The following is a description of a gene set: Regulation of pyruvate dehydrogenase (PDH) complex species: Homo sapiens Human Gene Set: REACTOME_REGULATION_OF_PYRUVATE_DEHYDROGENASE_PDH_COMPLEX, and this is the list of marker genes: PDHA1, PDP2, DLD, PDK3, PDK4, PDK1, GSTZ1, PDHB (pyruvate dehydrogenase E1 subunit beta), SIRT4, PDHA2, PDHX, DLAT, PDK2, PDPR, PDP1